The following is a description of a gene set: studied in species Homo sapiens Human Gene Set: GOBP_INSULIN_SECRETION The regulated release of proinsulin from secretory granules accompanied by cleavage of proinsulin to form mature insulin. In vertebrates, insulin is secreted from B granules in the B cells of the vertebrate pancreas and from insulin-producing cells in insects., and this is the list of marker genes: GAL, RPH3AL, ADRA2C, CCDC186, REST, BAD, CHRM3, MPC2, G6PC2, SIRT6, PCLO, NKX6-1, F2RL2, RBP4, LRP5, AACS, CCL5, GPLD1 (glycosylphosphatidylinositol specific phospholipase D1), IFNG, MCU, HNF1A, GCG, CD38, RAB11FIP5, TUNAR, FAM3D, TCF7L2, GNAS, ACVR1C, MIDN, CAPN10, OXCT1, PARK7, CDK16, CCN3, GLUD1, RAC1, FOXA2, SELENOT, PLCB1, SRI, SNX19, KLF7, BRSK2, PIM3, SYTL4, GNA11, ZBED6, CLOCK, CARTPT, TRPA1, RAPGEF3, NADK, PTPRN, GIP, PPP3CB, SREBF1, UCP2, PPARD, SOX4 (NCBI Gene Id 6659), PSMD9, KCNK16, ALOX5, NR1H4, HNF4A, ABAT, NNAT, VSNL1, NR1D1, IL6, TNF, SLC9B2, PICK1, RAPGEF4, RAB11FIP2, SYBU, TCIRG1, BLK, CHGA, PFKL, SLC2A2, SLC16A1 (solute carrier family 16 member 1), PRKN, IRS2, TARDBP, GPR27, PHPT1, GIPR, PDE8B (phosphodiesterase 8B), RIMS2, GPR119, IL1B, MLXIPL, LRRC8A, NR0B2, TFAP2B, PRKCA (protein kinase C alpha), CYB5R4, HIF1A, GNAO1, ADCY5, SIRT4, GNAI1, OSBP, NLGN2, UCN3, ADRA2A, RAB3A, ORAI1, MYRIP, ITPR1, MC4R, MTNR1B, DOC2B, PFKFB2, PTPN11, FOXO1, BAIAP3, NDUFAF2, STXBP4, CELA2A, FFAR1, CPLX3, VGF, SERP1, SIDT2, PTPRN2, ANO1, SMAD2, NOS2, NEUROD1, PLA2G6, SSTR5, GPER1, STX1A, GPR68, ENSA, SLC25A22, DYNLL1, INHBB (inhibin subunit beta B), GNAZ, RAB11B, GPRC6A, CAMK2G, ABCC8, F2RL1, RFX6, C1QTNF12, FKBP1B, ADCY8, ACSL4, ADCYAP1, RBM4, GHRL, KCNA5, HNF1B, FAM3A, IRS1, PER2, PRKAR1A, TM7SF3, BMP8A, CFTR, EPHA5, IL1RN, CASR, LEP, DRD2, GHSR, SIRT3, PRKCB, C2CD2L, FAM3B, PRKACA, TRPM5, EIPR1, CRH, TRH, PCK2, FFAR2, SNAP25, JAK2, SLC8B1, BMAL1, CPLX1, ENY2, CLTRN, STX4, PDX1 (pancreatic and duodenal homeobox 1), CPT1A, ILDR2, PFKM, RFX3, TRPM4, SLC30A8, NPFF, PRKCE, HADH, SYT7, KCNB1, GCK (NCBI Gene Id 2645), UQCC2, ABCA12, KCNJ11, F2 (NCBI Gene Id 14061), STXBP3, RAF1, EFNA5, ACVR2B, ISL1, HLA-DRB1, JAGN1, MAFA (NCBI Gene Id 389692)